Given this list of marker genes TSPAN15, TSPAN33, TSPAN9, SCIMP, GP6, TSPAN14, ADAM10, PDPN, CD81, SAMHD1, here is a description of the gene set: Human Gene Set: GOCC_TETRASPANIN_ENRICHED_MICRODOMAIN A pre-organized unit composed either of adhesion molecules (mainly integrins and members of the Ig superfamily), signaling receptors and/or enzyme-enriched plasma membrane domains that compartmentalizes cellular processes. Tetraspanin-enriched microdomains might be specially suited for the regulation of avidity of adhesion receptors and the compartmentalization of enzymatic activities. studied in species Homo sapiens